The following is a description of a gene set: species: Homo sapiens Human Gene Set: chr8p11, and this is the list of marker genes: RPL17P30, ENSG00000238966, LSM1, ZMAT4, RNU6-607P, RNF5P1, PLPP5, TM2D2, IDO1 (NCBI Gene Id 3620), VN1R46P, STAR, RNF170, HOOK3, NKX6-3, ASH2L, POMK, MIR548AO, RN7SL709P, PLEKHA2, TCIM, BAG4, PLPBP, FNTA, DKK4, RPL12P48, FGFR1, SNORD65B, TPT1P8, SNORD38D, RPS29P2, LINC01605, RN7SL806P, MIR4469, SIRLNT, IDO2, TACC1 (NCBI Gene Id 6867), ENSG00000308793, BRF2, THAP1, PLAT, DDHD2, ERLIN2, ADAM18, GPAT4, GINS4, GOT1L1 (NCBI Gene Id 137362), RNU6-988P, CHRNA6, CHRNB3 (cholinergic receptor nicotinic beta 3 subunit), RPL7AP80, IKBKB-DT, RN7SL149P, MIR486-2, LINC03042, SFRP1, SLC20A2, RNU6-323P, RPS20P22, ADAM3A (NCBI Gene Id 1587), RNU6-104P, ANK1, ADGRA2, SMIM19, NSD3 (nuclear receptor binding SET domain protein 3), HGSNAT, ADAM32, ADAM9, SMARCE1P4, ADAM5, IKBKB, RNU6-356P, ENSG00000183154, MIR486-1, POTEA, RPL3P10, VDAC3, RPL7L1P17, KCNU1, AP3M2 (adaptor related protein complex 3 subunit mu 2), LETM2, LINC02866, RNU6-895P, KRT18P37 (keratin 18 pseudogene 37), AFG3L2P1, SNX18P27, ENSG00000201329, HTRA4 (HtrA serine peptidase 4), RAB11FIP1, RNA5SP264, CYP4F44P, KAT6A, GOLGA7, ENSG00000253363, GPAT4-AS1, ADRB3, RNU1-124P, EIF4EBP1, RPL5P23, ZNF703, POLB, ADAM2